The following is a description of a gene set: studied in species Mus musculus A homeostatic process in which the lens is maintained in a highly refractive, transparent state to allow for optimal focusing of light on the retina. Mouse Gene Set: GOBP_MAINTENANCE_OF_LENS_TRANSPARENCY, and this is the list of marker genes: Apbb2, Muc5ac, Mip, Stk39, Vps13b (NCBI Gene Id 97991), Chmp4b, Gcnt2, Foxc1 (NCBI Gene Id 17300), Aldh1a1